Given this list of marker genes Rac3, Crk, Dbnl, Agrn, Kbtbd6, Gabarap, Abi2, Tiam1, Eps8, Eps8l1, Rhou (ras homolog family member U), Sh3bp1, Lrp4, Rac1, Garre1, Nf1, Kbtbd7, Rhog, Dok7, Farp2, Arhgap17, Kras, Auts2, Brk1, Als2, Elmo1 (engulfment and cell motility 1), Pik3cg, Dynlt1b (NCBI Gene Id 21648), Dock5, Dynlt1f, Aif1, Nckap1, Dynlt1c, Cyfip1, Dnm2, Cadm4, Dynlt1a, Rtn4, Ogt, Crkl, Wasf2, Arhgap44, Tns3, Nisch, Camk2d, Ssx2ip, Arf6, Eps8l2, Cdh13, Fnta, Rasgrf1, Farp1, Stmn3, Arhgap24, Dock2, Pik3cb, Wasf1, Musk, here is a description of the gene set: Mouse Gene Set: GOBP_RAC_PROTEIN_SIGNAL_TRANSDUCTION An intracellular signaling cassette in which a small monomeric GTPase of the Rac subfamily relays a signal. studied in species Mus musculus